Given this list of marker genes L2HGDH, D2HGDH, ADHFE1, here is a description of the gene set: The two stereoisomers of 2-hydroxyglutarate are normally converted to 2-oxoglutarate in the mitochondrial matrix, and can then be metabolized by the citric acid cycle. The physiological sources of 2-hydroxyglutarate have not been established although plausible hypotheses are that it is generated by lysine breakdown or as a byproduct of delta-aminolevulinate metabolism. The stereoisomers are oxidized to 2-oxoglutarate in FAD-dependent reactions catalyzed by the enzymes D2HGDH (specific for R(-)-2-hydroxyglutarate) and L2HGDH (specific for S(-)-2-hydroxyglutarate). An inherited deficiency in either enzyme is associated with accumulation of 2-hydroxyglutarate and variable neurological symptoms. R(-)-2-hydroxyglutarate also reacts reversibly with succinate semialdehyde to form 4-hydroxybutyrate and 2-oxoglutarate, catalyzed by ADHFE1. No deficiencies of this enzyme have been found in patients with elevated 2-hydroxyglutarate levels. species: Homo sapiens part of: Aerobic respiration and respiratory electron transport Reactome Pathway: Interconversion of 2-oxoglutarate and 2-hydroxyglutarate